The following is a description of a gene set: This event has been computationally inferred from an event that has been demonstrated in another species.<p>The inference is based on the homology mapping from PANTHER. Briefly, reactions for which all involved PhysicalEntities (in input, output and catalyst) have a mapped orthologue/paralogue (for complexes at least 75% of components must have a mapping) are inferred to the other species. species: Mus musculus Reactome Pathway: CD209 (DC-SIGN) signaling part of: C-type lectin receptors (CLRs) electronically inferred by orthology from the curated human pathway, and this is the list of marker genes: Relb, Pak3, Prkacb, Rela, Cd209a (NCBI Gene Id 170786), Prkaca, Ep300, Hras, Nfkb1, Icam2, Fyn, Rps6ka5